Given this list of marker genes FAM83D, CDCA7, MNS1, FAM204A, KNL1, TOR3A, MTMR1, MCM7, DONSON, DTL, MESD, MIR3939, CDCA7L, KIF20B, SPC25, TMSB15A, GAS2L3 (growth arrest specific 2 like 3), PDLIM3, E2F7, PTBP3, GPALPP1, ZNF367, KIF4A, NCAPH, MED30, MTFR2, PSMC3IP, POLD3, CENPF, ELAVL1, CDCA2, AURKA, CDC45, CEP55, KIF2C, CENPK, DDIAS, CENPN, KIF11, TRIP13, GPC6, RFC5, HJURP (Holliday junction recognition protein), TPX2, CDC6, JKAMP, PCLAF, CENPH, MYBL1, ENDOD1, CPED1, AQP3, ERI1, CDKN2C, KIF20A, MELK, CDCA8, MORC4, CIP2A, here is a description of the gene set: Genomic aberrations of Cyclin D1 (CCND1), CDK4, and CDK6 in neuroblastoma indicate that dysregulation of the G(1) entry checkpoint is an important cell cycle aberration in this pediatric tumor. Here, we report that analysis of Affymetrix expression data of primary neuroblastic tumors shows an extensive overexpression of Cyclin D1, which correlates with histologic subgroups. Immunohistochemical analysis showed overexpression of Cyclin D1 in neuroblasts and low Cyclin D1 expression in all cell types in ganglioneuroma. This suggests an involvement of G(1)-regulating genes in neuronal differentiation processes which we further evaluated using RNA interference against Cyclin D1 and its kinase partners CDK4 and CDK6 in several neuroblastoma cell lines. The Cyclin D1 and CDK4 knockdown resulted in pRb pathway inhibition as shown by an almost complete disappearance of CDK4/CDK6-specific pRb phosphorylation, reduction of E2F transcriptional activity, and a decrease of Cyclin A protein levels. Phenotype analysis showed a significant reduction in cell proliferation, a G(1)-specific cell cycle arrest, and, moreover, an extensive neuronal differentiation. Affymetrix microarray profiling of small interfering RNA-treated cells revealed a shift in expression profile toward a neuronal phenotype. Several new potential downstream players are identified. We conclude that neuroblastoma functionally depend on overexpression of G(1)-regulating genes to maintain their undifferentiated phenotype. from publication Molenaar JJ, Ebus ME, Koster J, van Sluis P, van Noesel CJ, Versteeg R, Caron HN (PMID 18413728) studied in species Homo sapiens Human Gene Set: MOLENAAR_TARGETS_OF_CCND1_AND_CDK4_DN Genes commonly down-regulated in SK-N-BE cells (neuroblastoma) after RNAi knockdown of CCND1 and CDK4.